Given this list of marker genes NPY (NCBI Gene Id 4852), VPS35, ABAT, ATP2B4, MIR21, PARK7, ITGAM, ACMSD, FSHR, DRD4, CHRNB2, SLC6A3, ALDH2, GPR37, SNCA (synuclein alpha), PAOX, TACR3, HPRT1, PNKD, DRD1, PRKN, HTR1A, NT5DC2, ATP7A (NCBI Gene Id 613259), NR4A2, ITGB2, here is a description of the gene set: Human Gene Set: GOBP_REGULATION_OF_AMINE_METABOLIC_PROCESS studied in species Homo sapiens Any process that modulates the frequency, rate or extent of the chemical reactions and pathways by which individual cells transform amines.